Given this list of marker genes Pkp1, Eif4ebp2, Fech, Polr2g, Eif5b, Bank1, Hbb-bs, Paip2, Tmed2, Rpl13a, Pml, Boll, Ythdf3, Eif3b, Uhmk1, Mettl3, Eif2s1, Eif1, Ddx3x, Mknk1, Eif2b5, Eif2ak1, Bc1, Zfp598, Dhx29, Rxra, Khdrbs1, Nck2, Tnf, Eif3k, Mtor, Eif4g2, Eif4ebp1, Ctif, Ncbp2, Impact, Habp4, Sh3bgrl, Klhl25, Ago2, Dazl (deleted in azoospermia-like), Eif4g1, Ppp1r15a, Paip1, Eif5, D1Pas1 (DNA segment, Chr 1, Pasteur Institute 1), Fmr1, Rbm4, Dnajc3, Bzw1, Ythdf1, Rps6kb1, Mif4gd, Ppp1r15b, Larp1, Akt2, Ythdf2, Ncbp1, Bzw2, Eif4e2, Eif4ebp3, Rps6kb2, Eif2ak3, Tpr, Nck1, Npm1, Paip2b, Scrib, Gigyf2, Eif2ak4, Alkbh1, Eif2ak2, here is a description of the gene set: Mouse Gene Set: GOBP_REGULATION_OF_TRANSLATIONAL_INITIATION Any process that modulates the frequency, rate or extent of translational initiation. studied in species Mus musculus